The following is a description of a gene set: The directed killing of a gram-negative bacterium by a neutrophil. Human Gene Set: GOBP_NEUTROPHIL_MEDIATED_KILLING_OF_GRAM_NEGATIVE_BACTERIUM studied in species Homo sapiens, and this is the list of marker genes: F2, F2RL1 (F2R like trypsin receptor 1), DAO, CXCL6, TREM1, TUSC2 (tumor suppressor 2, mitochondrial calcium regulator), ELANE